The following is a description of a gene set: Mouse Gene Set: GOMF_HYDROLASE_ACTIVITY_HYDROLYZING_O_GLYCOSYL_COMPOUNDS species: Mus musculus Catalysis of the hydrolysis of any O-glycosyl bond., and this is the list of marker genes: Man2b1, Glb1l, Gla, Spam1, Edem3, Naglu, Glb1l2, Otogl, Gne, Myorg, Man2a1, Amy2a2, Cemip, Chia1, Edem1, Lalba, Gm1110, Gba1, Ganab, Neu3, Chil6, Man2a2 (mannosidase 2, alpha 2), Cemip2, Glb1l3, Ctbs, Amy2a5, Ovgp1, Gba2, Lyz1, Man1b1 (NCBI Gene Id 277406), Spaca5, Amy2a1, Chil3, Hpse, Mgam, Agl, Pgghg, Klb, Oga, Lyzl4, Man2c1, Nagpa, Amy2a3, Lyg2, Amy2a4, Glb1, Man2b2, Lyg1, Lyz3, Sis, Engase, Kl, Treh, Hyal4, Man1a2, Adprs, Hyal1 (hyaluronoglucosaminidase 1), Amy1, Chil4, Fuca1, Mgam2-ps, Edem2, Mogs, Man1a, Neu4, Hexd, Neu2, Lctl, Neu1 (neuraminidase 1), Lyz2, Manea, Hyal3, Ganc, Gaa, Idua, Lct, Spaca3, Manba, Parg, Abhd10, Hexa, Chi3l1, Ugt1a6a, Chit1, Chil5, Gusb, Galc, Fuca2, Gm2a (NCBI Gene Id 552880), Hyal5, Gbe1, Hyal2, Naga, Lyzl1, Hexb, Lyzl6 (NCBI Gene Id 69444), Man1c1, Otog, Maneal